Given this list of marker genes KANK1, ABI3, MIR214, PLXNB3, SLIT2, ARPIN, CFL1, MIR196A1, HRG, here is a description of the gene set: studied in species Homo sapiens Human Gene Set: GOBP_NEGATIVE_REGULATION_OF_LAMELLIPODIUM_ORGANIZATION Any process that stops, prevents or reduces the frequency, rate or extent of lamellipodium organization.